The following is a description of a gene set: studied in species Homo sapiens Any process that activates or increases the frequency, rate or extent of the chemical reactions and pathways resulting in the formation of cholesterol. Human Gene Set: GOBP_POSITIVE_REGULATION_OF_CHOLESTEROL_BIOSYNTHETIC_PROCESS, and this is the list of marker genes: PRKACA, SREBF1, ABCG1, MBTPS2, SREBF2, PAQR3, PRKAA1, MIR182, FGF1, MAPK1, KPNB1, CYP7A1 (cytochrome P450 family 7 subfamily A member 1), MIR96 (microRNA 96), GNAI1, QKI, SCAP, ABCG4